Given this list of marker genes SOX9, B9D2, CC2D2A, TCTN2, MKS1, TMEM237, B9D1, TMEM67, TXNDC15, RPGRIP1L, TCTN3, TMEM107, TMEM231, TCTN1, CSPP1, TMEM216, RPGRIP1, CEP290, NR5A1, SRY (sex determining region Y), WT1, here is a description of the gene set: The presence of both ovarian and testicular tissues either in the same or in opposite gonads. Affected persons have ambiguous genitalia and may have 46,XX or 46,XY karyotypes or 46,XX/XY mosaicism. True hermaphroditism Human Gene Set: HP_TRUE_HERMAPHRODITISM species: Homo sapiens